Given this list of marker genes IL36G, IL1RL2, IL36RN, IL1F10, IL36A, IL1RAP, IL36B, here is a description of the gene set: species: Homo sapiens Reactome Pathway: Interleukin-36 pathway Interleukin-36 alpha (IL36A), IL36B and IL36G are collectively known as IL36. They are members of the Interlukin-1 family that signal through a receptor composed of Interleukin-1 receptor-like 2 (IL1RL2, IL36R) and Interleukin-1 receptor accessory protein (IL1RAP, IL-1R/AcP) to promote inflammatory responses. Interleukin-36 receptor antagonist protein (IL36RN, IL36Ra) is a natural antagonist. IL36 is expressed predominantly by epithelial cells and is implicated strongly through functional and genetic evidence in the pathology of psoriatic disorders. part of: Interleukin-1 family signaling